The following is a description of a gene set: species: Homo sapiens Human Gene Set: HP_DECREASED_CIRCULATING_GONADOTROPIN_CONCENTRATION Decreased circulating gonadotropin concentration A reduction of the circulating level of a gonadotropin, that is, of a protein hormone secreted by gonadotrope cells of the anterior pituitary of vertebrates. The primary gonadotropins are luteinizing hormone (LH) and follicle-stimulating hormone (FSH)., and this is the list of marker genes: LGR4, KISS1R, OTX2, TERT, BAP1, PIK3CA, PNPLA6, PDGFB, NR0B1, SUFU, NF2, SMARCB1, SEMA3A, TAC3, LHX4, AKT1, FEZF1, FSHB, SNRPN, NDN, PRDM13, LHX3, MANF, LHB, ROBO1, NHLH2, GNRH1, KISS1, PROP1, CPE (carboxypeptidase E), SMO, OCA2, TRAF7, MAGEL2, SMARCE1, DMXL2, HESX1, ANOS1, POU1F1